Given this list of marker genes Tent2, Ncor2, Yy1, Zfp512b, Rela, Hdac4, Bmp4, Srf, Lilrb4b, Pparg, Lilrb4a, Nfatc4, Hdac2, Pdgfb, Hif1a, Sox9, Rest, Qki, Nfatc3, Tgfbr1, App, Nfib, Ep300, Twist1, Smad3, Tgfb1, Gata6, Ppara, Ppard, Rara, Ncor1, Esr1, here is a description of the gene set: species: Mus musculus Mouse Gene Set: GOBP_NEGATIVE_REGULATION_OF_MIRNA_METABOLIC_PROCESS Any process that stops, prevents or reduces the frequency, rate or extent of miRNA metabolic process.